The following is a description of a gene set: Any process that modulates the frequency, rate or extent of the chemical reactions and pathways resulting in the formation of hemoglobin, an oxygen carrying, conjugated protein containing four heme groups and globin. studied in species Homo sapiens Human Gene Set: GOBP_REGULATION_OF_HEMOGLOBIN_BIOSYNTHETIC_PROCESS, and this is the list of marker genes: LDB1, EIF2AK1, SLC25A37, KLF4, FECH, PRMT1, ABCB10, SLC6A9